Given this list of marker genes IL6, TNF, IFNG, TYMS, IL1B, XIAP, HIF1A (NCBI Gene Id 3091), VEGFA, CCND1, BCL2, CFLAR, BCL2L1, CCNA2, STAT5A, BIRC5, here is a description of the gene set: Genes whose transcription is down-regulated by histone deacetylase inhibitors. from publication Marks PA (PMID 17322921) The path to the discovery of suberoylanilide hydroxamic acid (SAHA, vorinostat) began over three decades ago with our studies designed to understand why dimethylsulfoxide causes terminal differentiation of the virus-transformed cells, murine erythroleukemia cells. SAHA can cause growth arrest and death of a broad variety of transformed cells both in vitro and in vivo at concentrations that have little or no toxic effects on normal cells. It was discovered that SAHA inhibits the activity of histone deacetylases (HDACs), including all 11 known human class I and class II HDACs. HDACs have many protein targets whose structure and function are altered by acetylation including histones and non-histone proteins component of transcription factors controlling gene expression and proteins that regulate cell proliferation, migration and death. SAHA is in clinical trials and has significant anticancer activity against both hematologic and solid tumors at doses well tolerated by patients. A new drug application has been approved for SAHA (vorinostat) treatment of cutaneous T-cell lymphoma. studied in species Homo sapiens Human Gene Set: MARKS_HDAC_TARGETS_DN